Given this list of marker genes CFB, GZMA, ANPEP (alanyl aminopeptidase, membrane), F12, PROC, CPN1, FAP, BAAT, NAPSA, PLCG2, FURIN, ACE, CTSC, UBD, CTSL, CAPN5, C1S, TPSAB1, HMGCS1, DPP4, IGF1, LIPC, CFI, ENPEP, CAPN2, GALE, APOC3, XPNPEP1, FOLH1, PLA2G2A, HMGCS2, CTSE, ALDH5A1, MMP3, CPM, PEPD, F2, CPA3, MMP1, ACOX2, LIPA (lipase A, lysosomal acid type), LYZ, CASP1, PRSS23, ACY1, NEDD8, HPN, CELA3A, APOC1, MMP9, PLG, CTSS, ADAM9, APOC2, MMP13, PLA2G7, OLR1, MMP14, GALT, PLAU, PLAT, PSMB9, CTSB, KLK6, C1R, GZMB, F10, MST1, CPB2, LAP3, TIMP1, PRSS2, MMP7, CTSD, PRSS8 (NCBI Gene Id 5652), MMP2 (matrix metallopeptidase 2), PROZ, PRDX6, CTSO, HP, CTSK, BMP1, C2 (NCBI Gene Id 12263), AEBP1 (AE binding protein 1), TMPRSS2, MMP11, WFDC2, CHIT1, SORD, KLK10, LGMN, CASP4, MMP15, GZMK, PGC, MMP12 (NCBI Gene Id 4321), here is a description of the gene set: Human Gene Set: MODULE_172 Genes in the cancer module 172. species: Homo sapiens